The following is a description of a gene set: Human Gene Set: MIR8057 Genes predicted to be targets of miRBase v22 microRNA hsa-miR-8057 in miRDB v6.0 with MirTarget v4 prediction scores > 80 (high confidence targets). species: Homo sapiens from publication Chen Y, Wang X (PMID 31504780), and this is the list of marker genes: AQP11, UBN1, NRAS, GALK2, NTRK3, RAB7A, CNOT4, EYA4, NEURL4, CRYBG3, BBX, SLC39A10, HIBADH, SLC9A8, BCL2L2, PDE8A, TCAIM, SERPINB1, ANP32B, C4orf19, RAB27A, SAV1, RC3H1, SP1, E2F4, CNOT9, WDR37, ZDHHC23, CEP43, QTRT2, OSBPL10, HMGA2, CLOCK, BICRAL, PHF20, UBXN7, ARL13B, TSC22D2, NCAM2, BLZF1, BRD10, SERTAD2, SETD5, ADCY1, ELOVL6, SYNJ1, CACNA1D, SHROOM2, RYBP, STX3, PI4K2A, KIF1B, RFK, KIAA1549L, CMPK2, NTN5, SMAD4, TPD52, CCDC50, PDS5B, SPTSSA, BMPER, MAX, BIRC6, DERL2, KLK9, KLF12, TLCD5, ANKRD11 (ankyrin repeat domain containing 11), SDC2, CCDC186, PDXK, CCDC6, KCNJ3, CHURC1, DIXDC1, ADAM12, KRT32 (keratin 32), MTMR2, ZC3H12C (NCBI Gene Id 85463), C4orf3 (NCBI Gene Id 401152), CLASP1, RXFP1, ITPR1, RAD51D, TNPO1